Given this list of marker genes JARID2, DCUN1D2, CNOT8, EPRS1, IL12RB1 (interleukin 12 receptor subunit beta 1), UBR1, RLIM, IPO4, SHMT1, JAGN1, FAM86B2, BCL2A1, GCSH, ALS2, WHAMM, GNL2, ATP10A, RRP36, THRAP3, AARSD1, NUP214, GANAB (NCBI Gene Id 5312), APOBEC2, JMJD6, PHF6, KLF3, FLNB, POP1, UTP11, SRRM1, LRP10, ODC1, MYO1E, SLFN13 (NCBI Gene Id 146857), ABI3, NUDCD1, ENOX2, RBM14, SPATA13 (NCBI Gene Id 221178), RRP9, ZC4H2, LETM1, ARID1B, C8orf76, PYCR3, DCXR, ADI1, SPATA6, PPP1R7, CYP11B1, MRS2, RGS1, KANSL3, RBM7, SMARCA5, MYEF2, PSMB10, CCAR1, POGLUT2, NFATC3 (nuclear factor of activated T cells 3), FAM162A, GSTO1, RNF157, CSTF3, TMEM176B, PTPN2, PPARGC1B, KCNMB4, HSPD1, PSMD12, PFKL, USP34, RRS1, LRRC42, GNAS, GAA, NDUFS7, ORC3, CELA1, PFKP, KDM3A, ANKRD37, TUT4, TFPI, FBXL17, RBM5, SLC35D1, SMYD4, EIPR1, GALK1, LZTR1 (NCBI Gene Id 8216), NEK7, TAP1, TMEM70, CDK4, ZNF622, AQR, CYP2D6, BRWD1, AP3M2, TRMT6, KDSR, JUND, OLA1, NAE1, CDC5L, PSIP1, MAP3K1, NME7, RINT1, INSYN1, TTC13, NKRF, NDRG3, MAGED2, FYTTD1 (NCBI Gene Id 84248), GCDH, TARS3, REV3L (REV3 like, DNA directed polymerase zeta catalytic subunit), KIAA0753, EIF2AK4, FAM8A1, PDXK, CYSLTR2, GNB1L, FAU, ZNF707, POLE2, EARS2, PYCR2, CYP4V2, LDB1, METTL15, PDLIM1, ABCA4, ZNF266, SLC52A2, PHF20, IL21R, DUS3L, PARP2, ANAPC16, TRPM4, TRIP12, DBP, NXF1 (NCBI Gene Id 10482), SWI5, NCBP2, PYCARD, BRMS1L, UBXN2A, TSR3, PRXL2C, NCMAP (non-compact myelin associated protein), DOHH, APOOL, KCNA7, NRXN1, RAB3IP, C10orf88, GOSR2, LUC7L3, RPAIN, EIF3K, TTLL12, CREBBP, GPAM, ERAP1, FH, PPFIA1, MRPS18B, POLD2, RABEP2, RRP1, PLPP1, MACROH2A1, MAP2K7, TAF1C, NUP85, BOP1, PPP4R4, AMMECR1L, DUSP2, AKAP9, MRTFB, ZNF496, GRAMD1C, RNF114, DHCR7, PTPA, N6AMT1, LCMT2 (leucine carboxyl methyltransferase 2), KIAA0319, GNPNAT1, DHX33, UBE3A, IMMP1L, PWWP2A, SLC22A5, IFI35, here is a description of the gene set: from publication Konuma T, Nakamura S, Miyagi S, Negishi M, Chiba T, Oguro H, Yuan J, Mochizuki-Kashio M, Ichikawa H, Miyoshi H, Vidal M, Iwama A (PMID 21540074) Genes up-regulated in comparison of CD4 T cells versus neutrophils. Human Gene Set: GSE27786_CD4_TCELL_VS_NEUTROPHIL_UP species: Homo sapiens Each fraction of mouse hematopoietic cells was purified by cell sorting from bone marrow of 8-week-old C57BL/6 mice, and its gene expression was analyzed.